Given this list of marker genes KCND3, TMEM43 (transmembrane protein 43), ABCC9, AKAP9, MYBPC3, PRDX1, ENPP1, CASQ2, CPT1A, SCN10A, KCNJ5, KCNQ1, GBA1, TGFB2, KCNH2, DPP6, ACAD9, EIF4H, ANK2, PRKAG2, SCN4B, MYL2, GTF2IRD2, SMAD3 (SMAD family member 3), TRDN, SCN3B, DSP, SLC25A20, PKP2, CLIP2, LRP6, PTPN22 (NCBI Gene Id 5779), DNAJC19, GNB2, PIGA, MYH7, RAB3GAP2, PCSK9, CACNA1C, SLC4A3, ALPK3, DSC2, RANGRF, ACTN2, NCF1, ABCA3, ACADVL, RFC2, CRLF1, SCN2B, SCNN1A, DNAJC30, TECRL, TANGO2, ELN, ABCG8, KCNJ8 (potassium inwardly rectifying channel subfamily J member 8), CACNB2, TNNI3K, CSRP3, TPM1, SCN5A, SGCD, RYR2, GNAI2, IPO8, SFTPB, NUP155, KCNE1, TMEM270, BUD23, KCNE5, DTNA, TOR1A, TGFBR2, GPD1L, GTF2I, ABCA12, DES, METTL27, MRPL12, SMAD2, APOB, SLMAP, BAZ1B, TBL2, EMD, KCNE2, SFTPC, LDB3, TBX5, CAV3, CALM3, SYNE1, MMACHC, TNNT2, SNTA1, SCO2, TTN, TNNC1, FLNC, NOS1AP, DSG2, MYL3, HLA-B, IFT56, PGM1, TRPM4, CALM1, GTF2IRD1, PPA2, AGK, ABCC6, IKZF1, KLHL24, ACTC1, CRELD1, C1QBP, FKBP6, VPS37D, WIPF1, LDLRAP1, NDUFA2, SLC2A10, TGFB3, AKT1, LMNA, FHL1, KCNE3, JUP, CRLS1, TNNI3, MYOZ2, LIMK1, HMGCL (3-hydroxy-3-methylglutaryl-CoA lyase), SCN1B, FHOD3, RBM20, CLCF1, TGFBR1, SYNE2, P4HA2, LEMD2, HLA-DRB1, STX1A (syntaxin 1A), LDLR, ALG10B, EYA4, KCNJ2, ABCG5, SEMA3A, TSPYL1, CALM2, SLC19A2, CACNA2D1, WAS, HCN4, NDUFB11, here is a description of the gene set: Human Gene Set: HP_CARDIAC_ARREST Cardiac arrest studied in species Homo sapiens An abrupt loss of heart function.